Given this list of marker genes UBE2V2, TCF7L1, PLEKHO2, ADAM8, OXSM, FNTA, LINC00645, CYLD (CYLD lysine 63 deubiquitinase), FUT11, ZBTB25, BNIP3, SNX20, SIAH2, ABCF1, HIP1, ESCO1, NFKB1, MGARP, CYC1, BZW1, ORC1, MTFP1, PPP1R14B, P4HA1, ZNF395, BRPF3, NXF1, KDM4B, POFUT1, SNAPC1, GUK1, DDX41, HLCS, PGAM1, THUMPD3, NFKBIA, RANBP2, COX20, MRGBP, CLK1, BRI3, SULF2, KDM3A, GYS1, AMDHD2, HSPG2 (heparan sulfate proteoglycan 2), PIGA, TFRC, ERO1A, RNMT, HK2, EDEM1, RLF, NFKBIE, SH3D21, PLIN2, NARF, RNF19A, ZNF654, DDIT4 (NCBI Gene Id 54541), TNFRSF1B, MAPK1IP1L, PHC2, IL18BP, STK10, PKD2, PKM, PIK3IP1, ICOSLG, MGAT1, BHLHE40, FGF16 (fibroblast growth factor 16), B9D1, TMF1, HPCAL4, HDHD5, EXOSC4 (exosome component 4), ALKBH5, PARP6, TRIML1, SLC43A3, IRF2BP2, OSM, DIPK2A, CRYBB2, PDCD2L, ITPRIP, ALDOA, NOD2, NUP58, ATG9A (autophagy related 9A), RCAN2, ADM, PSMA6, ZNF331, UFSP2, GPAT4, TGFBR1, ICAM1, IFNGR2, RELA, GPAA1, RAB33A, ENSG00000291149, CBX5, LONP1, MYPOP, ZBTB1, RIOK3, GRPEL1, KDM5C, DDX18, SERPINE1, ETV5, IL1RAP, VPS18, ZFAND2B, ANKRD37, FFAR3, BNIP3L, SAP30, SF3A1, SAMTOR, NGLY1, LMNTD2-AS1, KCTD11, GRAMD1A, MUC6, MFSD10, ENO1, TPI1, SQSTM1, RASSF7, GPR146, DAP, PHF1, ZNF292, KRTAP19-3, OPA3, HILPDA, FKBP15, TNIP1, LDHA, GSTM3, ASCC1, DUSP3, LINC01743, CCDC107, TRIM28, C4orf3, MIF, FAM162A, SEC24A, RBPJ, HCAR3, RTL8C, PDXK, EFNA3, PRKAG2-AS2, MFAP1, RNF227, CXorf65, TNFRSF8, GPI, FEM1C, CTDP1, GBE1, RIMKLA, TAF9B, LGALS8, SLC25A21-AS1, PDK1, ARHGDIA, MAPK7, PGK1, VDAC1, CPNE5, NFXL1, ANKZF1, LZTS2, DDX50, FNDC3B, VGLL4, IRGC, ZNF770, INTS13, PPP1R36, IZUMO4, PGM1, GNA15, FAM210A, PIK3R5, RBM8A, SAR1B, ALDOC, MYNN, here is a description of the gene set: Genes down-regulated in comparison of control polymorphonuclear leukocytes (PMN) at 6 h versus PMN treated with F. tularensis vaccine at 6 h. species: Homo sapiens Human Gene Set: GSE37416_CTRL_VS_6H_F_TULARENSIS_LVS_NEUTROPHIL_DN from publication Schwartz JT, Bandyopadhyay S, Kobayashi SD, McCracken J, Whitney AR, Deleo FR, Allen LA (PMID 22986450) We demonstrated recently that both constitutive and FAS-triggered apoptosis of human neutrophils are profoundly impaired by Francisella tularensis, but how this is achieved is largely unknown. To test the hypothesis that changes in neutrophil gene expression contribute to this phenotype, we used human oligonucleotide microarrays to identify differentially regulated genes in cells infected with F. tularensis strain LVS compared with uninfected controls. In order to examine the effect of F. tularensis on the neutrophil transcriptome, we performed microarray expression analysis on human neutrophils treated with F. tularensis subsp. holarctica live vaccine strain (LVS).